Given this list of marker genes 3a, E, S, N, M, SARS coronavirus, complete genome, 7a, here is a description of the gene set: species: Homo sapiens part of: Late SARS-CoV-2 Infection Events This COVID-19 pathway has been created by a combination of computational inference from SARS-CoV-1 data (https://reactome.org/documentation/inferred-events) and manual curation, as described in the summation for the overall SARS-CoV-2 infection pathway.<br><br>The structures of complete SARS-CoV-2 virions, as well as their assembly stages, have been elucidated in great detail by cryo-electron microscopy methods. In particular, the Spike trimer is localized to ERGIC or Golgi compartments upon coexpression of E or M, which prevents syncytia formation. It is then transported via small transport vesicles to assembly sites. Based on work done in related coronaviruses, viral assembly is expected to occur at the ERGIC membrane. Membrane protein components of the virus concentrate at the ERGIC membrane but are also found throughout the secretory system including at the plasma membrane. Accumulation at the site of viral assembly has been shown to depend on interaction between retrieval signals in the cytoplasmic tails of viral proteins and host factors such as the COPI coat, and likely involves repeated rounds of anterograde and retrograde traffic.<br>Viral assembly is initiated by homotypic interactions of M protein. This forms an M-lattice that contributes to the induction of membrane curvature and additionally acts as a scaffold for the recruitment of the other structural components of the virus. M protein makes interactions with each of the main components of the mature virus, including E, S and N. Electron micrographic studies suggest the final size of the mature virus is ~100 nm. The ribonuclear particle is predominantly helical and is packaged with an outer diamter of ~ 16 nm. These physical constraints suggest a final stoichiometry in the mature virion of 75 S trimers:1200 M proteins:300 N:1 RNA genome. Minor amounts of other viral proteins, including proteins E, 3a and 7a may also be components of the mature virus, although their functions are not well established. Reactome Pathway: Virion Assembly and Release_9694322